The following is a description of a gene set: Nucleotide metabolism. studied in species Homo sapiens Human Gene Set: MODULE_337, and this is the list of marker genes: SRPK1, ZIC2, BYSL, PRPS2, DLEU2, ALMS1, PADI3, CD70, PRPF38A, MRTO4, SNRPA, UCK2, NUP50, ANKEF1, MDM1, HDAC2, NME2, IFRD2, ARHGAP11A, GMNN (NCBI Gene Id 51053), UTP18, NUP205, GPSM2, ZNF706, SLC25A37, ORC1, ZNF490 (zinc finger protein 490), MAS1L, NFYA, CABYR, DDX21, PMCHL1 (NCBI Gene Id 5369), SPEF2, SAC3D1, RRM1, DONSON, NUP155, ALG3, NCAPD2, PLK4, ACLY, ZBTB5, IER3, SEMA4B, CDC45, NME1, ADSL, PLGRKT, E2F1, SLC30A10, METAP1, RRM2, NUP88, KCNN4, HLCS, RAB6B, MDC1 (mediator of DNA damage checkpoint 1), CENPF, ILF3, HPRT1, RFPL3S, AHCYL2, PLEKHA8, POLA1